The following is a description of a gene set: Human Gene Set: DESCARTES_FETAL_LIVER_HEMATOPOIETIC_STEM_CELLS The gene expression program underlying the specification of human cell types is of fundamental interest. The study authors generated human cell atlases of gene expression and chromatin accessibility in fetal tissues. For gene expression, the study authors applied three-level combinatorial indexing to >110 samples representing 15 organs, ultimately profiling ~4 million single cells. The study authors leveraged the literature and other atlases to identify and annotate hundreds of cell types and subtypes, both within and across tissues. Our analyses focused on organ-specific specializations of broadly distributed cell types (such as blood, endothelial, and epithelial), sites of fetal erythropoiesis (which notably included the adrenal gland), and integration with mouse developmental atlases (such as conserved specification of blood cells). These data represent a rich resource for the exploration of in vivo human gene expression in diverse tissues and cell types. studied in species Homo sapiens Marker genes curated from the annotated cluster as represented in the Descartes Human Gene Expression During Development database. from publication Cao J, O'Day DR, Pliner HA, Kingsley PD, Deng M, Daza RM, Zager MA, Aldinger KA, Blecher-Gonen R, Zhang F, Spielmann M, Palis J, Doherty D, Steemers FJ, Glass IA, Trapnell C, Shendure J (PMID 33184181), and this is the list of marker genes: ENSG00000260316, CDH9, RNF220, TFAP2E-AS1, LINC01538, KIT, LINC02160, CHRM3, LINC02981, ICA1-AS1, CPNE7 (copine 7), NOG, NKAIN2 (NCBI Gene Id 154215), PRSS57, LINC01122, MPO, TNFRSF10A, HSPE1-MOB4, USP6, CFAP92, LINC02839, CALN1, PRDM16, INPP5J, HOXA7, ANKRD20A5P, HMGA2-AS1, MS4A3, SPINK2, HOXA6, CHRDL1, ENSG00000239572, AZU1, PRTN3, HTR1F, C1QTNF4, TRH